The following is a description of a gene set: from publication Zaslavsky E, Hershberg U, Seto J, Pham AM, Marquez S, Duke JL, Wetmur JG, Tenoever BR, Sealfon SC, Kleinstein SH (PMID 20164420) studied in species Homo sapiens Genes down-regulated in comparison of control conventional dendritic cells (cDC) at 0 h versus cDCs infected with Newcastle disease virus (NDV) at 6 h. The dendritic cell (DC) is a master regulator of immune responses. Pathogenic viruses subvert normal immune function in DCs through the expression of immune antagonists. Understanding how these antagonists interact with the host immune system requires knowledge of the underlying genetic regulatory network that operates during an uninhibited antiviral response. In order to isolate and identify this network, we studied DCs infected with Newcastle Disease Virus (NDV), which is able to stimulate innate immunity and DC maturation through activation of RIG-I signaling, but lacks the ability to evade the human interferon response. To analyze this experimental model, we developed a new approach integrating genome-wide expression kinetics and time-dependent promoter analysis. We found that the genetic program underlying the antiviral cell state transition during the first 18-hours post-infection could be explained by a single regulatory network. Gene expression changes were driven by a step-wise multi-factor cascading control mechanism, where the specific transcription factors controlling expression changed over time. Within this network, most individual genes are regulated by multiple factors, indicating robustness against virus-encoded immune evasion genes. In addition to effectively recapitulating current biological knowledge, we predicted, and validated experimentally, antiviral roles for several novel transcription factors. More generally, our results show how a genetic program can be temporally controlled through a single regulatory network to achieve the large-scale genetic reprogramming characteristic of cell state transitions. Human Gene Set: GSE18791_CTRL_VS_NEWCASTLE_VIRUS_DC_6H_DN, and this is the list of marker genes: STX11, CLK1, TRIM22, CFAP73, SP100, RTCB, SPC24, MX1, CSRNP1, OAS3, BLTP3A, STAT2, IFIT3, ZNF618, CCNA1, GTF2B, NUP58, APOL1, SEMA4D, TNFSF10, DHX58, SP110, SP140L, PNPT1, PPP4R1L, PHACTR4, B4GALT5, TRIM14, ERRFI1, CMPK2, STARD5, PAPOLG, NR4A3 (nuclear receptor subfamily 4 group A member 3), RNF138, MX2, BRIP1, TLK2, SIGLEC1, PML, STOML1, TENT4A, IRF1, TRIM25, TGIF1, SFT2D2, PIWIL4, SLC31A2, UNC93B1, IFI44L, KITLG, DERL1, PELO, RNF144A, PARP12, SOS1, IRF7, IFIT5, ARHGAP27 (Rho GTPase activating protein 27), MFN1 (mitofusin 1), TSSK4, ZBED1, DDX59, ZSCAN12, GBP1 (NCBI Gene Id 2633), GLRX, SQOR, IFI6, SAMD9L, MIR155HG, PMAIP1, UBE2Z, FMR1, TRANK1, DIPK1B, ISCA1, CCL8, RLF, PARP14, IL15, GCH1, NAMPT, DDX60, CARINH, SRGAP2, NLRC5, CXCL11, FUT4, RIGI, ISG20, PPP3CC, DCP1A, CXCL9, RTP4, CYLD, SMCHD1, STX17, GTPBP2, BATF2, USP42, DTX3L, GRHL1, PATL1, OASL, ABTB2, MYD88, PARP9, TMEM268, DYNLT1, MASTL, CD274, RAD9A, RUBCN, ADAR, GBP5 (guanylate binding protein 5), SELENOI, SECTM1, ZNRF2, NEXN, ISG15, DNAJB4, TRIM5, MYADM, STAT1, HERC6, KPNA5, DDIT4, RAB9A, NINJ1, CXCL10, TAP1, TBX2, SAMD9, ANKFY1, AURKB, SLC25A28, HELZ2, MAK, ZBP1, RNF213, FEM1C, AGAP2, RSAD2, FGF11, GPR180, C1GALT1, XAF1, SHFL, MORC3, IFI44, CMTR1, ADM, PTK2B, USP18, C3orf38, CRLF2, TRIM56, INKA1, KIF2A, TRIM69, ZNF107, USPL1, IFIT2, ACOT9, APOBEC3G, HERC5, ZNFX1, GPBP1, HK2, CNP, GNA13, PGAP1, EPSTI1, DMXL1, BCL3, DDX60L, PLSCR1, TGM1, IFIT1, RGL1, TOR1B, TMEM140, OAS2, NCOA7, ZBTB43, PHF11, PAWR, IFIH1, TENT5A, TMEM39A, ANGPTL4, SETD4 (NCBI Gene Id 54093), SBK1, SLC15A4, ST3GAL5, TGFB2, NT5C3A, ACTR10, RNF43